The following is a description of a gene set: Human Gene Set: HP_CONGENITAL_HEMOLYTIC_ANEMIA species: Homo sapiens Congenital hemolytic anemia A form of hemolytic anemia with congenital onset., and this is the list of marker genes: GYPC, PKLR, SPTB, PIEZO1, KCNN4, EPB41, SPTA1, SLC4A1